Given this list of marker genes Foxk1, Ces1b, Ces1a, Star, Acbd7, Kmo, Erlin2, Acss2, Trim63, Cyp26b1, Ido1, Aldoa, Etfb, Rdh1, Scd3, Lypla1, Slc16a1, Ces1d, Prkag3, Aldoart2, Htd2 (hydroxyacyl-thioester dehydratase type 2), Sik2, Cyp2d10, Tigar, Aoah, Cyp4f13, Cyp2d26, Srebf1, Pklr, Park7, Slc25a12, Twist1, Slc27a1, Plp1, Sord, Nr5a2, Hsd17b4, Cthrc1, Fgf15, Ier3, Myo5a, Hadhb, Hoga1, Mgat4a, Tecr, Fah, Abcd2, Slc45a3, Nucb2, Mcrip2, Acly, Ptges, Insig1, Hpgd, Khk, Ltc4s, Ceacam1 (NCBI Gene Id 26365), Htt, Slc16a3, Hadha, Th, Mlx, Apoc2, Scd1, Prmt3, Cyp2c39, Apoc2l, Pparg, Acoxl, Nudt19, Slc27a6, Pnpla8, Cyp4v3, Scap, Cyp4a10, Lipg, Lcn5, Cbr4, Gsta1, Ivd, Alox12 (NCBI Gene Id 11684), Pex5 (NCBI Gene Id 19305), Adipor2, Hsd17b12, Them5, Apoc1, Acat2, Fabp3, Dhrs9, Pex7, Bckdk, Errfi1, Gatm, Prkab2, Aldob, Slc27a2, Auh, Aldh1l2, Decr1, Cnr1 (NCBI Gene Id 12801), Acot7, Slc4a4, Alox15, Acad12, Ahr, Esrrb, Lipe (NCBI Gene Id 71060), Uchl1, Akt2, Slc27a4, Ugt2a1 (UDP glucuronosyltransferase 2 family, polypeptide A1), Sesn2, Ubr4, Daglb, Lpgat1, Cpt2, Pnliprp2, Ptgr2 (prostaglandin reductase 2), Crat, Akr1c13, Sds, Akr1c18, Aldh1a3, Me1, Pgk1, Cyp4a30b, Abat, Ndufab1, Gpi1, Acbd5 (acyl-Coenzyme A binding domain containing 5), Acaa1b, Mpi, Cyp26a1, Cyp2c40, Pdpn, Hacd3, Elovl6, Fads6, Kat2b, Abhd2, Cyp7b1, Cpt1c, Fgfr4, Fabp6 (NCBI Gene Id 16204), Mlst8, Pdhb, Pex13, Alox5, Pgam2, Nudt8, Cpt1b, Lipc, Prkag2, Phgdh, Pnkd, Adh5, Acsl1, Ins1, Cyp2f2, Mecr (NCBI Gene Id 26922), Prxl2c, Fmo2, Ces2c, Pfkfb2, Ldha, Pck1, Acat1, Npc1, Akr1b1, Acsm3 (acyl-CoA synthetase medium-chain family member 3), Ddit4, Acot11, Gpam, Edn1, Akr1c12, Pfkm, Arl2, Acsm5, Hal, Ces1h, Mgst3, Arnt, Appl2, Elovl3, Abhd5 (abhydrolase domain containing 5), Dhtkd1, Pnlip, Sult2a8, Ghsr, Elovl1, Acnat1, Hacl1, Eci2, Stard4, Cyp1b1, Pdha2, Acnat2, Hk3, Galt, Fabp4, Pdk4, Acadsb, Acadl, Kyat1, Lias, Slc38a1, Cyp2j11, Gstp1, Srr, Ogdh, Cygb, Pdhx, Myc, Abcc9, Atp6v1b1, Cyp2c38, Cyp4a29, Adipor1, Pdzd11, Ldhd, Akr1c6, Hyi, Tecrl, Aldh1a2, Pla2g3, Gpx1, Eno2, Cyp2a12, Cyp3a16, Nat8l, Cyp2j8, Abhd1, Cyp7a1, Malrd1, Pex2, Alox12e, Nudt7, Nr1h3, Rdh16f2 (RDH16 family member 2), Dcxr, Alox12b, Acads, Rdh10, Etfbkmt, Cyp2d22, Acot3, Acsm4, Irs2, Rgn, Elovl5, Mtch2, Peds1 (NCBI Gene Id 98887), Ndufs6, Actn3, Sirt1, Pecr, Fabp5, Insr, Akr1a1, Edn2, Hacd2, Gstp2, Agxt, Dgat2, Akr1c21, Idh1, Echdc2, Bdh2, Per2, Thnsl2, Slc25a17, Anxa1, Trp53, Sirt4, Cyp4a12b, Cyp2a22, Tpk1, Zbtb7a, Cyp2j9, Bco2, Gba2, Ces2b, Grhpr, Lpl, Mfsd8, Pank2, Cyp2e1, Alkbh7, Pnliprp1, Adh4, Acot8, Slc5a6, Aldh5a1, Rdh16, Cyp2j13, Acot2, Gpat4, Gpx4, Slc22a13, Brca1 (NCBI Gene Id 12189), Htr2a, Pdk2, Hpgds, Src, Pgam1, Akr1c19, Faah, Agt, Por, Ptgr1, Acsbg3 (acyl-CoA synthetase bubblegum family member 3), Acsl3, Dlat, Aldh3a2, Cyp4a32 (NCBI Gene Id 674313), Pgk2, Aasdh, Cyp3a41a, Acox3, Acot5, Cyp3a41b (NCBI Gene Id 100041375), Ugt1a6a, Prkaa1, Slco1a6 (NCBI Gene Id 73773), Etfdh, Acsm2 (acyl-CoA synthetase medium-chain family member 2), Elovl7, Kit, Cyp2c50, Eci1, Mapk9, Rdh9, Cyp4f40, Me3, Prox1, Ldhc, Kynu, Cyp2j5, Cyp2c37, Acaca, Enpp1, Ces2a, Abcc2 (NCBI Gene Id 12780), Aacs (acetoacetyl-CoA synthetase), Pla2g4a, Lpin3, Cyp2a4, Agxt2, Ces2h, Mgll, C3, Cyp27a1, Plin5, Sphk1 (NCBI Gene Id 66122), Angptl3, Gcdh, Ggt5, Psen1 (NCBI Gene Id 19164), Cyp4a14, Hnf1a (HNF1 homeobox A), Echdc1 (enoyl Coenzyme A hydratase domain containing 1), Bcl2l13, Vnn3, Klhl25, Them4, Naaa, Pnpla3, Hagh, Pck2, Il4i1, Acad9, Comt, Pla2g4d, Ptges3 (NCBI Gene Id 80424), Nupr1, Nr1h4, Ogt, Cyp2a5, Hsd17b8, Apoa4, Cyp2b13, Il1b, Lep, Cyp2c29, Tnxb, Acot9, Cyp2d9, Gstp3, Rbp1, C1qtnf2, Ces2e, Cyp2u1, Adtrp, Akr1d1, Ucp2, Fads1, Ppara, Acadm, Rptor, Aldh1a7, Adipoq, Jmjd8, Ankrd23, Mid1ip1, Haao, Gck (NCBI Gene Id 14624, glucokinase), Prkaca, Acot6, Hk2, Ces2g, Hadh, Flcn, Ankrd26, Dbi, Hao2 (hydroxyacid oxidase 2), Hif1a, Elovl4, Ces1c, Ceacam2, Haghl, Acox1, Bmncr, Vdac1, Sgpl1, Pdk3, Git1, Blvra, Ces2f, Irs1, Dgat1, Apoc3, Acsbg2, Ftcd, Mir199a-2, Ncor1, Mapk14, Ptges3-ps (NCBI Gene Id 670174), Cpt1a, Aldh8a1, Mcat, Trib3, Pibf1, Akr1cl, Pfkp, Aldoart1, Hlcs, Acsl6 (acyl-CoA synthetase long-chain family member 6), Pla2g2a, Cyp3a44, Cyp2c55, Sirt2, Myog, Pon3, Gatd1, Gad1, Fads3, Pla2g15, Cp, Cav1, Eno3, Cyp3a11, Acot12, Pfkfb3, Mlxipl, Gamt (guanidinoacetate methyltransferase), Cyp1a1, Mfsd2a, Crabp2, Scp2, Eif6, Sox9, Pfkl, Acsf2, Nr1h2, Fasn (NCBI Gene Id 353049), Prkag1, Gstp-ps, Eno1, Qki, Acsl5, Hao1, Ephx2, Lonp2, Pla2g10, Sp1, Pla2g2f, Mtln, Ptgis, Phyh, Akr1b7, Gstm4, Fmo4, Prxl2b, Pam, Slc1a3, Eno4, Ins2, Idh2, Insig2, Erfe, Gdf15, Asah2, Pla2g4f, Cbfa2t3, Amacr, Dbil5, Cyp4a31, Abcd3, Cyp2g1, Erlin1, Cyp2s1, Echdc3, Lypla2, Acsbg1, Fmo1, Acot1, Acss1, Cyp4f18, Btd, Olah, Gk, Ehhadh, Gip, Trex1, Dagla, Me2, Snca, Cyp2w1, Elovl2, Ppp2ca, Alox5ap, Asah1, Slc2a6, Mlycd, Bpgm (2,3-bisphosphoglycerate mutase), Abcb11, Igf1, Zbtb20, Dld, Lpin2, Ugt2a2, Mblac2, Tkfc, Pcx, C1qtnf9, Aloxe3, Adpgk, Degs1, Acsf3, Gstm7, Avpr1a, Cyp2j12, Abhd3, Cyp2t4, Tnfrsf1a, Aig1, Fkrp, App, Nr1d1, Mthfd1l, Stat3, Pla2g5, Adh1, Scd4, Gapdhs, Xylb, Cyp26c1, Rdh19, Glyat, Lpin1, Ces1e (carboxylesterase 1E), Il3, Cyp2c23, Mrs2, Ces1f, Acacb, Ptgs2, Nfe2l1, Decr2, Cyp2b23, Ldhb, Fa2h, Hacd1, Cyp4f14, Acaa2, Aspa, Gad2, Ep300, Mir214, Sirt6, Sco1, Acot4, Hkdc1, Abcd4, Acad10, Cyp2b19, Glo1, Cryl1, Apoa5, Scd2, Mtor, Acaa1a, Ces1g, Akr1c20, Vnn1, Crot (NCBI Gene Id 74114), Tysnd1, Cyp4a12a, Ilvbl, Acox2, Arv1, Gapdhrt, Alox8, Hacd4, Aldh1a1, Mpc2, Etfa (NCBI Gene Id 52321), Cyp2d11, P2rx7 (NCBI Gene Id 18439), Slc27a5, Tyrp1 (tyrosinase-related protein 1), Cyp8b1, Ech1, Amdhd1, Abcd1, Prkaa2, Gstm6, Prkab1, Strap, Acsm1, Adh6b, Hk1 (hexokinase 1), Cyp2c54, Slc27a3, Cyp1a2, Galk1, Akt1, Ephx1, Fabp2, Pfkfb1, Col6a1, Uroc1, Hsd17b10, Foxk2, Eci3 (NCBI Gene Id 69123), Acadvl, Gpd1, Fads2, Adh7, Acsl4, Mif, Mthfd2, Ucp3, Ppard, Dcaf5 (NCBI Gene Id 320808), Cyp39a1, Eno1b, Avp, Fbp1, Echs1, Cyp2b10, Slc37a4, Plaa, Baat, Pla2g1b, Mpc1, Hnf4a, Ptgds (NCBI Gene Id 19215), Pm20d1, Cyp4f15, Oxsm, Atp8b1, Wdtc1, Mmut, Eif2ak3, Akr1c14, Cyp2d12, Pdk1, Fads2b, Gapdhrt2, Acad11, Gstm1, Obp2a, Tmem135, Cd74, Ldhal6b, Ppargc1a, Gstm3, Gstm2, Gale, Tbxas1, Lipa, Cyp2j7, Ptgs1, Prkar2b, Fabp1, Cyp2j6, Ifng, Tpi1, Cyp2b9, Pkm (NCBI Gene Id 18746), Adh6a, Pgd, Cyp2d34, Cyb5a, Ptges2, Pdha1, Aldoc, Hdac4, Gapdh, Slc4a1, Klf9, Shmt2, here is a description of the gene set: The chemical reactions and pathways involving monocarboxylic acids, any organic acid containing one carboxyl (COOH) group or anion (COO-). species: Mus musculus Mouse Gene Set: GOBP_MONOCARBOXYLIC_ACID_METABOLIC_PROCESS